Given this list of marker genes H2-M3, Clec12a, Zbtb46, Tmem176a, Tmem176b, here is a description of the gene set: species: Mus musculus Any process that stops, prevents or reduces the frequency, rate or extent of dendritic cell differentiation. Mouse Gene Set: GOBP_NEGATIVE_REGULATION_OF_DENDRITIC_CELL_DIFFERENTIATION